The following is a description of a gene set: species: Homo sapiens Human Gene Set: chr14q23, and this is the list of marker genes: UBA52P3, ZBTB1, RPPH1-2P, RPL31P5, ACTR10, DAAM1, SCOCP1, RNU6-341P, KCNH5, GPHB5, EIF2S2P1, SIX4, LINC02324, ARID4A, SRMP2, LINC00216, HSPA2 (heat shock protein family A (Hsp70) member 2), RNU6-597P, RPL9P5, LRRC9, TOMM20L, TRMT5, MIR4708, MIR4706, SYT16 (synaptotagmin 16), ENSG00000259118, AKR1B1P5, ZBTB25, RN7SKP99, PARP1P2, RMB8AP1, PLEKHG3, RPL31P4, PCNX4-DT, HNRNPCP1, SERTAD4BP, SLC38A6, RNU7-116P, GARIN2, ENSG00000254718, TEX21P, C14orf39, JKAMP, SALRNA1, PRKCH, PTBP1P, MIR5586, ATP5F1AP4, SALL4P7, AKAP5, PSMA3P1, RAB15, PPM1A, FUT8 (NCBI Gene Id 2530), GPHN, SGPP1, MNAT1, LINC02290, LINC01303, RNU2-14P, RNU6-398P, PCNX4, HIF1A, YBX1P1, ENSG00000307479, ESR2, RNU6-1162P, MIR548H1 (microRNA 548h-1), DHRS7, LINC01500, LINC00644, MIR625, SNAPC1, PSMA3-AS1, PPP1R36, COX4I1P1, FTH1P13, ATP6V1D, GPX2, RPL17P2, SIX1, KIAA0586, PPP2R5E, MTHFD1, TIMM9, HSPA2-AS1, CCDC196, MAD2L1P1, HSPE1P2, RHOJ, PPIAP5, MIR7855, FUT8-AS1 (NCBI Gene Id 648120), LINC03033, SYNE2, NUP50P1, PALS1, ENSG00000258926, EIF1AXP2, CHURC1-FNTB, RN7SL598P, HMGB1P14, SIX6, NCOA4P1, PRKCH-AS1, SF3B4P1, RTN1, FNTB, RPL36AP2, MAX, SLC35F4, RPS28P1, GNRHR2P1, TMEM30B, SPTB, GPR135, PSMA3, CCDC175, DACT1, L3HYPDH, GCATP1, ARMH4, LINC02322, CHURC1, WDR89, EIF2S1, HSBP1P1, RPL21P7, RPL21P8, TOMM20L-DT